Given this list of marker genes GFRA1, RBP4, BMP4, NCOA4, EIF2B5, GAS2, IMMP2L, UBE2Q1, UTF1, MKKS, FOXL2, SIRT1, SOX15, SRY, BIK, RAC1, TAF4, SOX9, HMGB2, RETN, YBX3, NTRK1, FGF8, HOXD13, GATA6 (NCBI Gene Id 2627), ZFP42, HOXA11, STAT5B, NUP210L, FSHB, COL6A1, CCND1, NIPBL, BAK1, ATM, CASP3, SRD5A1, PRKACG, ERCC1, ADAM29, NRIP1, AMH, TGFB2, SPATA22, FOXC1, FGFR2, ADAM15, PSAPL1, SFRP2, AR, RRM1, CDKN1B, SULF1, BASP1, LFNG, HMGA2, PCYT1B, MMP2, NR0B1, BMP6 (NCBI Gene Id 7964), KDR (kinase insert domain receptor), FKBP4, INHA (inhibin subunit alpha), ABCB1 (NCBI Gene Id 5243), FNDC3A, NOTCH4, BCAS2, TBC1D20, TEX19, TCF21, SERPINB5, BCL2L1, PRLR, CHD7, WNT9B, NASP, ATRX, SERPINF1, NKX3-1, TESC, MMP19, MEA1, LRP2, PDGFRA, MCIDAS, FGF10, DNAAF11, TYRO3 (TYRO3 protein tyrosine kinase), SMARCC1, PPP1R9B, ERRFI1, MERTK (NCBI Gene Id 10461), ARID5B, DMRTA1, SIX4, CRIP1, ASB1, BCL2L11, AMHR2, PRDX4, EIF2B4, LEP, NPPC, CDKN1C, VEGFA, DHCR24, FANCG, BAX, HSD17B4, H3-3B, CSDE1, DLG1, UBB, KDM5B (lysine demethylase 5B), PLEKHA5, STAT5A, NCOA1, FOXO3 (forkhead box O3), WDR19, ALOX15B, FOXF2, WNT5A, ESR1, ZFPM2, CCNO, TMF1, REN (NCBI Gene Id 5972), FANCA, PSAP, GDF7 (NCBI Gene Id 8873), INHBA, PGR, GMNC, SFRP1, C3, DNAAF3, NDUFS6, SRC (SRC proto-oncogene, non-receptor tyrosine kinase), TIPARP, ADAM20, TSPY3, KITLG, KIT, GATA1, IGF1, CEBPB, FGF9, HOXB13, HESX1, FEM1B, SMAD4 (SMAD family member 4), MMP14, RXFP2, WNT2B, RARG, MAMLD1, RBMY1B, BMP5, AXL, IDH1, CASP2, FST, RDH10, CGA, EAF2, EIF2B2, ANTXR2, SHH, GATA4, HYAL3, BRIP1, SCX, MSH4, PLAG1, SAFB2, ACE, TFAP2C, SLIT2, WNT4, AFP, ARID4B, NPR2, TSPY8, ARID4A, PTX3, ING2 (inhibitor of growth family member 2), NOG, TSPY2, SPATA2, RARA (NCBI Gene Id 5914), TEX11, ROBO2, KLHL10, AKR1C3, TSPY10, FLNA, TSPY1, SLIT3, SCAPER, CCDC182, UMODL1, BOK, INHBB, NOTCH1, ZP3, RAB13, CYP19A1, DHH, NUP107, CSMD1, PTPN11, SPO11, NR2F2, GLI1, HNF1B, TLR9, SOD1, H3-3A, NR5A1, STRA6, ADAM18, SALL1, ANG, GATA3, ASH1L, CTNNA1 (NCBI Gene Id 619480), MYOCD, WT1, HOXA10, PTCH1, ADAM2, INSR, REC8, IRX5, VGF, SOX8, ADAM21, BCL2, HOXA9, NEUROG1, DMRT1, TSPY4 (NCBI Gene Id 728395), SIX3, CYP7B1, STK11, TBX3, NKX2-1, BMPR1B, ODAD3, FANCE, LSM14B, ASPM, ADAM32, PKD1, OSR1, NUPR1, CTNNB1, RNF38, FRS2, TLR5, HOXA13, LHB, TNC, PATZ1, DHX37, MSH2, CITED2, LGR4, FER, EIF2S2, SGPL1, GPR149, FZD4, LHCGR, SRD5A2, LHX1, NOS3, PLEKHA1, TSPY9, UBE3A, WNT7A, ADAM30, DNAJC19, CBL, LHX9, NR5A2, WDR77, WDR48, NHLH2, GNRH1 (NCBI Gene Id 2796), HSD17B3, TGFBR1, KIF18A, FOXA1, SYCP2, ZNF830, DCANP1, PRPS1L1, GDF9, ZFY, ADAMTS1 (ADAM metallopeptidase with thrombospondin type 1 motif 1), CD2AP, DMC1, CRKL, ID4, ACVR2A, TP63, FSHR, BCL2L2, BMP7, ADGRG1, PTPRN, EREG, BRCA2, TIFAB, RHOBTB3, SERPINE2, GREB1L, AGO4, TLR3, TNFAIP6, ATN1, here is a description of the gene set: Human Gene Set: GOBP_REPRODUCTIVE_SYSTEM_DEVELOPMENT studied in species Homo sapiens The progression of the reproductive system over time from its formation to the mature structure. The reproductive system consists of the organs that function in reproduction.